The following is a description of a gene set: Juvenile rheumatoid arthritis Human Gene Set: HP_JUVENILE_RHEUMATOID_ARTHRITIS studied in species Homo sapiens, and this is the list of marker genes: ACP5, LACC1, IL6, DCLRE1C (DNA cross-link repair 1C), MIF, HLA-DRB1